The following is a description of a gene set: studied in species Homo sapiens Human Gene Set: MODULE_408 Genes in the cancer module 408., and this is the list of marker genes: NSMAF, GM2A, SMPD1, HEXB, PLCG2, ASAH1, PLCD1, UGCG, NAGLU, GPX4, PLD1, NAGA, PSAP, ARSA, IMPA1, PLA2G5, PRDX6, HYAL1